Given this list of marker genes Mboat2, Pnpla8, Pla2g1b, Pla2g2f, Pla2g2d, Pla2g3, Pla2g6, Pla2g2a, Pla2r1, Plbd1, Pla2g5, Pla2g2e, Pla2g4d, Lpcat4, Pla2g4f, Pla2g12a, here is a description of the gene set: Reactome Pathway: Acyl chain remodelling of PE part of: Glycerophospholipid biosynthesis electronically inferred by orthology from the curated human pathway This event has been computationally inferred from an event that has been demonstrated in another species.<p>The inference is based on the homology mapping from PANTHER. Briefly, reactions for which all involved PhysicalEntities (in input, output and catalyst) have a mapped orthologue/paralogue (for complexes at least 75% of components must have a mapping) are inferred to the other species. studied in species Mus musculus